Given this list of marker genes CTHRC1, MMP1, STAT3, MSR1, PLA2G4A, COL7A1, ASCC1, here is a description of the gene set: Defect in the epithelium of the esophagus, essentially an open sore in the lining of the esophagus. species: Homo sapiens Human Gene Set: HP_ESOPHAGEAL_ULCERATION Esophageal ulceration